The following is a description of a gene set: Human Gene Set: MIR1303 Genes predicted to be targets of miRBase v22 microRNA hsa-miR-1303 in miRDB v6.0 with MirTarget v4 prediction scores > 80 (high confidence targets). species: Homo sapiens from publication Chen Y, Wang X (PMID 31504780), and this is the list of marker genes: MYO6, SAMD12, SEC24A, ASL, FAM9C, BOLL, ATRX, ZBTB41, MLF1, EXOC6B, ZNF69, BCL11A, RNF152, TNRC6B, ADAMTSL1, FAM199X, KLHDC10, KATNAL1, NTRK2, SECISBP2, TMEM108, RSBN1, MLLT3, KLHL7, PUM1, GOLGA6L4, OGFRL1 (opioid growth factor receptor like 1), CHEK1, CCDC148, TET1, ACTL6A, TET2, SLC35E3, RTKN2, MCOLN2, DNM3, COBL, KBTBD6, ST8SIA4, ANAPC16, CNTNAP2 (NCBI Gene Id 26047), EIF4E, NAA50, SLC25A53, GORAB, SCYL3, LSAMP, MOB3B (MOB kinase activator 3B), AGTR1 (angiotensin II receptor type 1), NOS3 (nitric oxide synthase 3), PDIA3, PHTF2, PIK3C2B, FOXO3, PYGO1, PSEN1, TCEANC, YWHAZ (NCBI Gene Id 83242), DCDC1, TPRG1, WDR7, SHQ1, PML, CLDN18, FAM81A, ATG3, IGSF1, CAMSAP2, POU4F2, EVI2A, IDS, ZNRF2, RIC8B, NALF1, PATZ1, AVL9, PAPOLB, STRBP, ABHD5, SGCB, MYLK, NETO2, EGR2, CXCL11, BLZF1, MGP, DTNB, TRNT1, TMEM151B, TNFAIP8L3, C8orf88, TRIM33, SNX2, PXDN, ZNF644, FOXR2, PRRC2C, UBXN2B, CAPN7, ZBTB6, FAM131A, ADRA1A, AOC3, FAM9A, NR4A3, BACH1, KCTD12, IPMK, SCN3B, NSMAF, PLCB4, TCERG1, P2RY14, BAG2, RRP15 (ribosomal RNA processing 15 homolog), EBF1, ITPRID2, PSMD7, SIRT2, GDF9, THSD7A, MAX, CA2, ERVFRD-1, RLIG1, PDE1C, SORCS1, XRRA1, ABCA13, SLC30A4, ZMAT1, ZNF605, DCK, ADH1B, EPHX4, PAGR1, CRIPT, PDGFD, NR3C1, TNPO1, UNC13C, GALNT13, NR2C1, AMACR, VWC2, TCF12, ZNF276, ATF6, ZNF217, SGIP1, OTOF, EOMES, PIKFYVE, ASF1A, C2orf69, TUBA1A, FAN1, MID1, TASOR, EFNA5, TRAF3, PEAK3, NR6A1, SETD7, PPP3CA, POLR2F, CLIC6, ENPP2, SH3YL1, TG, ARMC1, FBXL17, SH3BP4, DOP1B, DGKH, EEF1AKMT3, PTCH1, USP43, TAB2, GOLGA6L9, SIDT1, FRS2, SNX31, RNF182, L3HYPDH, COPS2, SLC35G1, LTBP1, AGMO, NRAS (NRAS proto-oncogene, GTPase), RBM28, RUNX2 (RUNX family transcription factor 2), STATH, RFLNB, ZHX3, NISCH, ACADL, ADAT1, ELOVL6, ANKDD1A, NOVA1, PI15, PPM1E, PAXIP1, CTSO, ALG10B, PMS1, CSNK1G3, ABCB5, CD46